Given this list of marker genes PSAT1, SLC3A2, YARS1, HSPA5, SARS1 (NCBI Gene Id 6301), OSER1, CEBPB, EPB41L4A-AS1, SNHG8, ARF4, EIF1B, GADD45B, CCDC174, SNHG15, MTHFD2, SQSTM1, ZNF622, DNAJB9, GARS1, PDRG1, SNHG32, DDIT4, NUPR1, HSPA9, SNHG12, RSRC2, TXNIP, STC2, SNHG7, ATF4, ZFAS1, PPP1R15A, CARS1, TAF1D, ASNS, ZFAND2A, XBP1, TRIB3, ATF3, BTG1, CEBPG, GDF15, DDIT3, SHMT2, WARS1, PHGDH, GADD45A, UPP1, MAP1LC3B, HERPUD1, here is a description of the gene set: studied in species Homo sapiens Human Gene Set: GAVISH_3CA_MALIGNANT_METAPROGRAM_7_STRESS_IN_VITRO from publication Gavish A, Tyler M, Greenwald AC, Hoefflin R, Simkin D, Tschernichovsky R, Galili Darnell N, Somech E, Barbolin C, Antman T, Kovarsky D, Barrett T, Gonzalez Castro LN, Halder D, Chanoch-Myers R, Laffy J, Mints M, Wider A, Tal R, Spitzer A, Hara T, Raitses-Gurevich M, Stossel C, Golan T, Tirosh A, Suvà ML, Puram SV, Tirosh I (PMID 37258682) Genes upregulated in subsets of cells of a given type within various tumors In this study, an extensive analysis was conducted to define meta-programs (MPs) capturing intra-tumor heterogeneity across a spectrum of tumor types. The approach utilized non-negative matrix factorization (NMF) to analyze each cell type separately within individual tumor samples. This involved the analysis of malignant cells, macrophages, fibroblasts, endothelial cells, epithelial cells, T-cells, and B-cells. NMF was executed with varying parameter values (K=4, 5, 6, 7, 8, 9), thereby generating 39 programs for each cell type per sample. Each NMF program was summarized by the top genes based on NMF coefficients.\nRobust MPs were then delineated for each cell type using a set of stringent criteria, including recurrence within the same tumor, similarity to programs in other tumors, and non-redundancy within a tumor. Subsequently, these robust NMF programs were clustered (per cell type) based on Jaccard similarity, leading to the identification of MPs associated with each cell type.\nTo enhance the quality of the MPs, a refinement steps were undertaken, involving the removal of MPs suspected of reflecting low-quality data (with an overrepresentation of ribosomal proteins or mitochondrial-encoded genes), single-study inclusion, or similarity to miss-annotated cell types.